The following is a description of a gene set: Any process that results in a change in state or activity of a cell or an organism (in terms of movement, secretion, enzyme production, gene expression, etc.) as a result of stimulus by estradiol, a C18 steroid hormone hydroxylated at C3 and C17 that acts as a potent estrogen. species: Homo sapiens Human Gene Set: GOBP_RESPONSE_TO_ESTRADIOL, and this is the list of marker genes: DUSP1, CRYAB, UCN, GSTP1, SLC6A4, IGFBP2 (insulin like growth factor binding protein 2), SSTR2, CD38 (NCBI Gene Id 952), TACR3, HSF1, CCDC62, ESR2, GHR, SLC34A1, KIF18A, AIFM1 (apoptosis inducing factor mitochondria associated 1), WNT8B, RUVBL2, ADCYAP1R1, POSTN, MYOD1, HNRNPD, FAM210B (family with sequence similarity 210 member B), GPX1 (glutathione peroxidase 1), F7, STAT5B (signal transducer and activator of transcription 5B), STRN3, CYP19A1, GHSR, SOCS2, ASS1, ENDOG, MBD3, ITGAM, DDX18, CTNNB1, DNMT3A, TGFB1, MMP15, MAP1B, OXT, CSN1S1, KAT5, CFLAR, ARNT2, ENO2, NCOA3, PTGFR, AREG, HTR5A, POU4F1, HPGD, NCOR2, CCNA2, PRKCA (NCBI Gene Id 5578), SRD5A1, MMP2, EZH2, GPER1, PTCH1, TXNIP, FGF10, SFRP1, CCND1, ALDH1A2, STAT3, MSX2, ABCB1, MBD2, MBD4, PCNA (proliferating cell nuclear antigen), CD4, MYOG, DHH (desert hedgehog signaling molecule), PPP1R9B, POU4F2, GH1, IHH, CASP3, CRHBP, RGS9, CALR, CASP8, RARA (NCBI Gene Id 5914), ESR1, EEF2, DRD2, SSTR1, STXBP1 (NCBI Gene Id 6812), H2AZ1, FOXA1, ARPC1B, GRIA1, NRIP1, LEP, LCOR, IL10, PENK, CAT, COL1A1, GPX4, ZNF703, WNT7A, RAMP3, TACR1, ITGA2, BMP7, GPI, EGFR, NR2F2 (NCBI Gene Id 7026), ERRFI1, NCOA1, CASP9